The following is a description of a gene set: Human Gene Set: GOBP_REGULATION_OF_INTERLEUKIN_6_MEDIATED_SIGNALING_PATHWAY species: Homo sapiens Any process that modulates the rate, frequency or extent of an interleukin-6-mediated signaling pathway., and this is the list of marker genes: C1QTNF4, MIRLET7C, MIR125B1, MIR146A, MIR26A1, PTPN2, MIRLET7E, MIR125A, MIRLET7A1, GFI1 (growth factor independent 1 transcriptional repressor), IL6ST, MIR98, MIR99A (NCBI Gene Id 407055), RIPK1